Given this list of marker genes HSP90AA1, YWHAG, SDCCAG8, TUBA4A, NME7, TUBGCP6, ALMS1, MAPRE1, CEP135, CEP192, CSNK1D, HAUS6, NEK2, PLK1, DCTN1 (dynactin subunit 1), DYNLL1, TUBGCP3, HAUS8, DYNC1I2, CSNK1E, HAUS5, CEP250, CEP41, CDK1, TUBB4B, YWHAE, PPP2R1A, CLASP1, CEP72, SSNA1, TUBG2, PCM1, HAUS7, ACTR1A, CEP152, TUBB4A, CDK11A, CEP78, TUBGCP5, CEP131, PRKAR2B, OFD1, PLK4 (NCBI Gene Id 27119), SFI1, HAUS1, HAUS2, NINL, CEP70, TUBGCP2, CDK5RAP2, PRKACA, DCTN3, ODF2, CDK11B, HAUS3, CENPJ, CKAP5, HAUS4, DCTN2, PCNT, CNTRL, AKAP9, CEP76, TUBGCP4, CETN2, CCP110, NDE1, MZT1, TUBB, DYNC1H1, CEP164, NEDD1, TUBA1A, CEP57, CEP63, TUBG1 (NCBI Gene Id 7283), CEP43, PAFAH1B1, CEP290, MZT2B, MZT2A, here is a description of the gene set: Human Gene Set: REACTOME_RECRUITMENT_OF_MITOTIC_CENTROSOME_PROTEINS_AND_COMPLEXES Recruitment of mitotic centrosome proteins and complexes species: Homo sapiens